Given this list of marker genes IGKC (NCBI Gene Id 3514), MET, IGF2R, PDGFRL, PIK3CA (NCBI Gene Id 5290), TP53, CASP8, BTK, IGHG2, AXIN1, APC, CIITA, CTNNB1, here is a description of the gene set: Human Gene Set: HP_VIRAL_HEPATITIS Viral hepatitis Inflammation of the liver due to infection with a virus. studied in species Homo sapiens